The following is a description of a gene set: Mouse Gene Set: GOBP_MALE_MATING_BEHAVIOR studied in species Mus musculus The specific behavior of a male organism that is associated with reproduction., and this is the list of marker genes: Ar, Esp22, Nlgn4l, Trpc2, Ncoa1, Ppp1r9b, Slc6a4 (solute carrier family 6 (neurotransmitter transporter, serotonin), member 4), Oxt, Hexb, Pten, Grin1, Nhlh2, Grn, Dmrta1, Hdac2, Hdac4